Given this list of marker genes PLET1, CLASP1, ADAM17, FERMT2, HBEGF, MTOR, WNT7A, ACVRL1, RREB1 (ras responsive element binding protein 1), MMP12, ITGB1, FERMT1, PTEN, ITGA5, LRG1, COL5A1, CLASP2, ITGAV, ARHGAP24, AJUBA, PHLDB2, MSX2, ITGB3, HTN1, FIGNL2, MIR221, ITGB5, here is a description of the gene set: studied in species Homo sapiens The migration of an epidermal cell along or through a wound gap that contributes to the reestablishment of a continuous epidermis. Human Gene Set: GOBP_WOUND_HEALING_SPREADING_OF_EPIDERMAL_CELLS